The following is a description of a gene set: Human Gene Set: MIR3192_5P Genes predicted to be targets of miRBase v22 microRNA hsa-miR-3192-5p in miRDB v6.0 with MirTarget v4 prediction scores > 80 (high confidence targets). from publication Chen Y, Wang X (PMID 31504780) species: Homo sapiens, and this is the list of marker genes: ADAM29, KLHL18, FNDC10, PRICKLE2, HMBOX1, GOLGA6L10, HIPK2, TMTC1, RBMS2, ELOB, FSHR, ANK1, SPINK7, UBP1, TMEM170A, XRN1, IRF2, NDUFC2-KCTD14, PHLPP2, FBXW7, GIGYF2, VAPA, ADTRP, SPOCK1, PITPNM2, CALN1, KHDC4, SPRED3, NID1, PDE3A, ADARB2, IQSEC3, NECTIN1, SLC7A14, CLIC5, UBASH3B, C1orf105, CNOT9, DHRS2, S100A5, MPZL1, SEPTIN1 (septin 1), SYNGAP1, GAL3ST4, SENP5, COPG2 (NCBI Gene Id 80038, COPI coat complex subunit gamma 2), CPEB1, ORAI2, DNM1L, NAV2 (neuron navigator 2), MYO1D, CNTLN, MDM4, MEN1, PTGIS, ALKBH8, VSTM4, COQ5, LDLRAP1, KCNQ4, CLIP3, KLHDC8A, GGT7 (NCBI Gene Id 2686), CLSTN1, SHISA7, METTL25B, WDCP, HCK, TMEM260, TIMP3, MT1E, SERPINA9, STK36, RNPEPL1, SBK1, SLC7A8, HOOK2, AVL9, GAL3ST3, PCGF3, BTNL8, MT1F, ATP8A2, CXCL12 (NCBI Gene Id 6387), KCNC1, AAK1, PLP1, GOLGA6L9, KATNIP, MYPOP, INPP5K, HEYL, FHDC1, ETS1, STRADB, SUSD5, NMNAT2, GOLGA6L4, SLCO2A1, LRRC59, APLP1, CBX5, STX1B, BTG1, KLF1, OSBPL3, ZNF629, GATA2, TAB1, TRIM4, TIMM23, YBEY, GRIA3, MT1M, DCAF8, CTNND2, CYP8B1, GRIP2, FAM120C, MTCL2, G6PC3, PSMB11, LYN, SH3PXD2A (NCBI Gene Id 9644), NRG1, ARRB1, PIM2 (Pim-2 proto-oncogene, serine/threonine kinase), FBXL7, ACVR1B, DNAJC11, SCRT2, CCDC149, KSR2, MYRF, KCTD14, LSM10, METTL21A (methyltransferase 21A, HSPA lysine), WDR26, ATRN, LPCAT2, PRELP, EXD2, NLGN3, SPPL2B, CDK5R1, SYPL2, ABHD2, MAPK8IP3, SH3TC2, TBL1XR1, ARHGEF39, P4HA3, N4BP1, TEAD1, SOX14, IGDCC4 (NCBI Gene Id 57722), CPD, EFR3B, SAV1, FGF11